The following is a description of a gene set: Mouse Gene Set: YAO_TEMPORAL_RESPONSE_TO_PROGESTERONE_CLUSTER_0 Genes co-regulated in uterus during a time course response to progesterone: SOM cluster 0. Human infertility and recurrent pregnancy loss caused by implantation defects are poorly understood. Hoxa-10-deficient female mice have severe infertility and recurrent pregnancy loss due to defective uterine implantation. Gene expression profiling experiments reveal that Hoxa-10 is an important regulator of two critical events in implantation: stromal cell proliferation and local immunosuppression. At the time of implantation, Hoxa-10 mediates the progesterone-stimulated proliferation of uterine stromal cells. Hoxa-10 mutants express a stromal cell proliferation defect that is accompanied by quantitative or spatial alterations in the expression of two cyclin-dependent kinase inhibitor genes, p57 and p15. Hoxa-10 deficiency also leads to a severe local immunological disturbance, characterized by a polyclonal proliferation of T cells, that occurs in place of the normal progesterone-mediated immunosuppression in the periimplantation uterus. from publication Yao MW, Lim H, Schust DJ, Choe SE, Farago A, Ding Y, Michaud S, Church GM, Maas RL (PMID 12554760) species: Mus musculus, and this is the list of marker genes: Lamb3, Pla2g7, H2-T23, Ngef, Sprr2f, Dkk3, Cyp4v3, Gabarapl1, Nr1d2, Vamp4, Lox, AW112010, Mxi1, Pros1, Nr1d1, Prom1, Smpdl3a, Ablim1, Eps8, Bnip3, Rtn2, Tef, Ypel3, Rin2, AU020206, Adrb2, Glns-ps1, Bach1, Cebpd, Rora, Aldoc, Mycl, Abca4, Ldaf1, St6gal1, Itih5, Enpp2, Ccng2, Nrep, Angptl2, Haus4, Rad51b (RAD51 paralog B), Ephx1, Cpd, Aox1, Epb41l4aos (erythrocyte membrane protein band 4.1 like 4a, opposite strand), Casp4, Met, Abca1, Sash1, Cfh, Lifr, Ncam1, Bbs9, 4833420G17Rik, Gstt2, Hsd17b11, Wdr45, Lama3, Reck, Map1lc3b (NCBI Gene Id 67443), Gem, Dbp, Ctsf, Atp1a2, Pnpla2, Sesn1, Nt5e, Crebrf, Alas1, Glrb, Foxp1, Txndc16 (NCBI Gene Id 97917), Klhl24, Ddx6, Igfbp3, Rhoq (NCBI Gene Id 80836)